Given this list of marker genes Pcx, Gad2, Ass1, Got1, Adsl, Got2, Crat, Dars1, Carns1, Aspa, Asl, Agxt (NCBI Gene Id 11612), Gad1 (glutamate decarboxylase 1), Abat, Gpt, here is a description of the gene set: Mouse Gene Set: WP_ALANINE_AND_ASPARTATE_METABOLISM Alanine and aspartate metabolism studied in species Mus musculus